Given this list of marker genes Gls2, Glud1, Pycr1, Got2, Oat, Rimkla, Pycr2, here is a description of the gene set: electronically inferred by orthology from the curated human pathway species: Mus musculus This event has been computationally inferred from an event that has been demonstrated in another species.<p>The inference is based on the homology mapping from PANTHER. Briefly, reactions for which all involved PhysicalEntities (in input, output and catalyst) have a mapped orthologue/paralogue (for complexes at least 75% of components must have a mapping) are inferred to the other species. Reactome Pathway: Glutamate and glutamine metabolism part of: Metabolism of amino acids and derivatives